Given this list of marker genes SRI, DNAJC5, CYB561, SYT2, ANXA7, DBH, SLC17A9, SYT1, ATP8A1, here is a description of the gene set: Human Gene Set: GOCC_CHROMAFFIN_GRANULE_MEMBRANE The lipid bilayer surrounding a chromaffin granule, a specialized secretory vesicle found in the cells of adrenal glands and various other organs, which is concerned with the synthesis, storage, metabolism, and secretion of epinephrine and norepinephrine. species: Homo sapiens